The following is a description of a gene set: Mouse Gene Set: GOBP_REGULATION_OF_TOLL_LIKE_RECEPTOR_9_SIGNALING_PATHWAY Any process that modulates the frequency, rate, or extent of toll-like receptor 9 signaling pathway. species: Mus musculus, and this is the list of marker genes: Zdhhc3, Rab7b, Ppt1, Ptpn22, Gramd4, Rsad2, Rtn4, Tlr9 (toll-like receptor 9), Treml4, Ptprs, Cd300ld3, Slc15a4, Hmgb1